The following is a description of a gene set: Human Gene Set: FOXN3_TARGET_GENES from publication Yevshin I, Sharipov R, Kolmykov S, Kondrakhin Y, Kolpakov F (PMID 30445619) species: Homo sapiens Genes containing one or more binding sites for (FOXN3) in their promoter regions (TSS -1000,+100 bp) as identified by GTRD version 20.06 ChIP-seq harmonization., and this is the list of marker genes: NCOA5, SNURF, NDRG2, SCN4A, ZNF22-AS1, ZC3H6, RNA5SP335, DPY19L1, RAB11FIP2, AGBL2 (AGBL carboxypeptidase 2), CD68, SPTAN1, MIR409, NR2F1, MUC2, GGT1, NEK10, CFAP58-DT, SNORD1C, LINC01237, PKD1L2, REC8, PER2, FBF1, SMG1P3, PCMTD2, RPN2, HIRA, TCTE1, TAF4B, MTF2, FAM90A1, ARMC3, ZC3H18, KRT8P51, ACACB, DLL1, RALB, EHHADH, C2orf92, EMC3, KIF23, HEXIM1, ESYT2, SEC23B, RPL35A, TP73-AS3, MCRIP1, OPTN, HSPA12B, ANXA2R, NDRG3, NEDD8, HAAO, JMJD1C, DLGAP4-AS1, AAMP, ROCK2, RSPH1, C4orf17, FAM86GP, TOM1L2, CRIM1, EXOSC6, SIGMAR1, GAD1, MIPEPP3, DNAJC25-GNG10, B3GNT2, OGFR, TCEA2, HNRNPF, LINC01191, AMBRA1, PGPEP1, HYMAI, TTC7A, FAT1, ARMCX2 (armadillo repeat containing X-linked 2), BBIP1, NEK11, RBKS, TMC8, CAP2, NKAIN2, SYNGAP1-AS1, SRP54, ZNF430, ZNF266, ENSG00000232188, DNAAF5, ZNF84, UBXN2B, RNU6-921P, DTX2, DNAH9, MICA, DNAH3, CEP112, CDH24, MBD3, FBXO36, MCF2L2, ARMC5, MUL1, GALT, CKLF-CMTM1, ZNF653 (NCBI Gene Id 115950), ANKRD42, ZNF460, MYLK-AS1, CXCL6, CCS, ISG15, USP40, CKLF, SNAI3-AS1, SORD, TRDMT1, PRC1, ZNF839, SPAG16, GTF3C1, TAT-AS1, RRBP1, HLA-J, SEC23A-AS1, LYPLA2P2, EFCAB11, UBXN2A, CREBL2, KCNQ1OT1 (KCNQ1 opposite strand/antisense transcript 1), LTA, MECOM, KAT14 (lysine acetyltransferase 14), RAMP2, AMFR, ELMOD2, LINC01388, PRDM5, TENT4B, INTS12, RNF213-AS1, LINC00708, RTF2, DNAJC25, CFLAR, MAT2A, CCDC103, PECAM1, STRBP, PRRT2, C20orf144, MDH1, DPY19L2P3, C12orf76, BHLHE41, CDH11, EFTUD2, NAA20, TYR, CREB1, ANG, LRRC43, TMEM74B, DNAH7, ASPHD1, MIR4466, ANKRD42-DT, EPAS1, KIF3C, BFSP1, KIF23-AS1, SLC35F3, ZNHIT2, FAM234A (NCBI Gene Id 83986), ATRAID, LINC01229, NELFA, TTC12-DT, VAPA, TCP11, MFSD9, FOSB, FBXO44, MATCAP1, H3P37, MUC3A, ZFHX2-AS1, SAMD10, PHF1, FKBPL, ZDHHC1, TRAV4, ETV7, MOCS3, SHOX2, TP53TG3GP, ITGB4 (NCBI Gene Id 3691), CNTD1 (NCBI Gene Id 124817), GEMIN2, TM7SF2, TMEM14B, MROH2A, PCTP, CACNB4, CEP250, SIN3A, MID1IP1, ADA, COX11, AKAP1-DT, KCTD2, ZNF324, GMDS-DT, GJC1, MVD, MHENCR, BTBD3, RUFY4, XRCC5, WDR59, FTCDNL1, CEACAMP2, SIRT3, TTLL6, KLHL18, PANK2-AS1, MLF1, PFN1, USP6NL, UBN2, KCNMB3, CHMP3, ALPI, TMEM39B, STK32C, HSPA4L, CLK3, ATF7IP2, DNAAF4-CCPG1, TADA2B, ESRP2, WFDC3, WBP2, ATP7B, MIR449C, MAP3K14, TRPC6, DGKD (diacylglycerol kinase delta), LINC02564, LINC00639, CEP120, AATK, SUPT5H, CEP41, SNORA50C, MRPL33, EYA2, MT2A, CEP131, C2orf42, ZCCHC17, TTLL5, RAVER2, TPBGL-AS1, GALNS, ATP6V1C2, PIGFP3, BABAM2, CHMP1A, CNEP1R1, SNRPN, B3GALT4, ATG4B, BCAS1, KATNIP, WDR93, MED23, ITGB3BP, IL4R, ALKBH8, RPTOR, PIK3R1, TMEM234, ENTPD6, MIR6081, CCDC121, SNHG10, NEIL1, IQCE, VAX2, SEMA4F, PRKD1, EXD3, PET117, SLC43A2, PEPD, CDCA8, ADGRA1-AS1, GSTA4, RSPH1-DT, LAMC1, PHLDB1, PEX12, TSGA10, NMUR1, USP36, MFF-DT, THAP4, ACOXL, PARAIL, MIR6784, P3H4, LINC00205, RCAN2, SIDT2, RPL23AP7, TRAPPC6A, ACVR2A, PTPN18, RIPK2, MRPL40, TAP2, SPPL2A, DNAL1, EIF6, PIGG, AHSA2P, LINC00426, CASC2, ARHGEF1, ZNF444P1, ARL4A, MRC2, RFC5, TMEM219, CKAP2L, MIR219A1, MPHOSPH10, PIERCE1, SDHAF4, MT-TP, ENSG00000267053, MIR933, GLRX5, FAM174C, PDE6G, BCL6B, KCNIP4, PDCD6-DT, EFCAB12, FBXO15, MON2, EZH1, TGIF2-RAB5IF, RNASE11, CAPS2, RUBCNL, OBSL1, B3GNT7, PKP2, CNOT8, WDR45B, SGK1, PYGB, WDR4P2, PTGES3L, CDH13-AS2, ITGB1BP1, CCDC148, LRP5, TTLL9, HOXD9, ANKEF1, USP24, PARD3B, ANKRD36, BLTP3B-DT, USP2-AS1, TRIB2, RANBP2, C20orf96, CFAP58, OTUD7A (NCBI Gene Id 161725), EIF3I, ITGA3, ACTRT3, LZTS3, C6orf136, ENSG00000277020, SNRPB2, DNAAF4, CYB561, CFAP144, IQCG, SLC4A7, PRADC1, ADGRG1 (NCBI Gene Id 9624), ALS2, TRPT1, PGM1, ZCRB1, EARS2, WARS1, SNRNP40, PPP1R9B, RCOR3, SLC8A1, DNAAF11, RBM39, CNGA4, AIRIM, PIGU, U2SURP, SDC1, BAD (BCL2 associated agonist of cell death), ZNRF2P2, RBM33-DT, PLCL1, SYNGAP1, ACSF3, TULP2, PCK2, AOPEP, LCAT, ABI2, PDXDC1 (pyridoxal dependent decarboxylase domain containing 1), ATP5ME, CHPF, RPL23, GOLM2, TEKT3, PAK1, ZGPAT, USP39, POLG2, C11orf97, PPM1G, FOXJ1, TUBD1, GSAP, TCTN1, TRIM65, NFATC4, NUDT22 (nudix hydrolase 22), ALG11, DCDC2C, PFN1P6, C2CD4A, CDT1, HEXD, RAB37, TOR2A, RRAGC-DT, COL18A1-AS1, SPATA4, FAM230C (family with sequence similarity 230 member C), PKDCC, EXOC3L4, LRFN5, SLC4A2, MIR3188, MIR4470, MIR221, RC3H2, PTMA, LIME1, RIPOR3, CFAP221, ODF2, GCC2-AS1, RGS17, PIK3R5, RBMS1, PDCD6, PAQR9-AS1, ATIC, LRRC45, SIRT5, SAMD12, PIEZO1, AHI1-DT, FLYWCH2, ADCY4, GNB1L, FGF11, AGXT, MCEE, PRKRA (NCBI Gene Id 94716), MBTPS1, BOK, NPAS2, WDR25, CTCF-DT, LINC02980 (NCBI Gene Id 124906555), LRP6 (NCBI Gene Id 4040), SNX29, AGBL5, MIR4730, ARL4C, PKD1P4, GRINA, WDPCP, CARMIL2, MFSD4B, TP53RK-DT, MPHOSPH6, ZNF217, ALG1, CARMIL3, EPN3, SPATA2, GGCX, ENSG00000282936, RAB40C, CACNG6, POLR1H, DSTN, DTNB, ANAPC1, ASXL1, CCDC30, COX6A1P2, TTLL4, NDRG4, UCHL1-DT, TTYH2, BAIAP2, MUC6, SLC16A14, RGS22, AIG1, MSL1, OGFOD3, SPRED2, TFB2MP1, PTRH1 (NCBI Gene Id 138428), GMPR2, SCLY, PPP1R7, EFCAB10, DENND6B, FAM187A, TBPL1 (TATA-box binding protein like 1), BBS5, RAB40B, MZF1, SLC1A4, RPS3AP1, CYBRD1, DNTTIP1, HSPB6, PRPSAP1, SSB, PPP4R4, HMGN3, GSTZ1, ENSG00000259881, CCM2L (CCM2 like scaffold protein), CFAP96, ZNF316, IL20RA, TNRC6A, FBRS, TRIP12, SMG1P1, ADGB-DT, RNF111, ZNF529, STXBP6, PHOSPHO2, ARHGDIA, FASN (fatty acid synthase), TIMP2, EIF1, SAMD14, YPEL5, CFAP43, LINC01934, SYCP2, LNPK, TMEM198, STK25, AHI1, RBM15-AS1, RSPH14 (radial spoke head 14 homolog), RUNDC1, STMP1, ZNF367, KPNA1, PPP1R2P10, AANAT, CLTB, SEMA4C, KIAA1671, TNRC6C, PHF3, LIMS2, HSBP1, CACNA1G, EFHC1, ARFGEF2 (NCBI Gene Id 10564), MGC16275, LINC02978, CCNB2, NRSN2-AS1, CFAP263, RBM12B-DT, ATP6V1G1P5, FOXF2, ARHGAP5-AS1, NDUFAF6, ACTR3, GLI2, MIR541, KCNAB2, MIR339, FAM161A, RBFOX3, THNSL2, EPCIP-AS1, PTPRA, FERMT1, ADI1, LYRM4, PCDHA5, MARCKSL1P2, IL34, WDCP, OSCP1, UQCC6, GPATCH2, RHOQP3, TMEM101, LASP1, PEX5, POLD3, SEC23A, PRSS12, NAPB, IFI35, KIF6, TGIF2, RIIAD1, MKS1, TOMM7, CCNO, PAXBP1, CENPX (NCBI Gene Id 6800), SNORA71D, CDR2-DT, PPM1B-DT (PPM1B divergent transcript), RAET1L, KLHL23, STK11IP, CCDC191, TMEM131, DM1-AS, CCDC39-AS1, MIPEP, PSMD10, PDE4DIPP8, SCO1, RAMP1 (NCBI Gene Id 10267), ENSG00000283291 (NCBI Gene Id 110467522, 5.8S ribosomal RNA), TBC1D16, RTKN (NCBI Gene Id 6242), TMEM225B, PJVK, KATNAL1, SNORC, TCFL5, CHKA-DT, IGKV1OR2-3, BRD2, GZF1, CDSN, BCL2L1, HGS, ZBTB9, TPTE, ATXN2L, C14orf119, DCBLD1, LRRC46, HSP90AB1, ZNF497, WBP1, MBTPS1-DT, DYNC1I2, ANTKMT, MORN2, PXDN, MTX1, CPAMD8, CBFA2T3, COL9A3, TFAP2C, CEP97, NAV3, METTL9, ATP5PDP1 (ATP synthase peripheral stalk subunit d pseudogene 1), RN7SKP152, MIR208B (microRNA 208b), VEGFB, RTL10, FNBP1, WDR90, CABIN1, NRL (NCBI Gene Id 4901), SLC2A10, HSD17B1, NDE1, ENSG00000260005, ARIH2, CDR2, NTSR1, PRUNE2, KDM8, MTCL2, NELFCD, LMCD1, FLII, FBLN7, COA3, SEPTIN10, PRKCD, MLF1-DT, GNAO1-DT, FAM217B, STX8, NRSN2, HELZ (NCBI Gene Id 9931), RHBDF2, IQANK1, KDM3A (NCBI Gene Id 55818), HDAC4, UAP1, RNF157-AS1, KIF17, KIFC3, FHIP1B, WTAP, AP1S3, ADISSP, CARS2, PARD6A, RABGGTA, RPS20P5, CEP43, SCARNA13, SPEG, TOP2B, LGALS3BP, ARID1B, LRGUK, PLEKHG4, NPAS3, SFT2D1 (SFT2 domain containing 1), H2AC15, USP34, POLE4, DCTN1, ANAPC7, USP34-DT, SPATA20, CAMTA2, CCT7, ZBBX, RABL2B, HCG25, PANK2, SMARCD2, SCUBE3, FAM182B, ARFGAP1, SKIDA1, RALGAPA1, ZNF747-DT, TMEM232, P3H2, GGCTP1, PANX1, HID1, TK2, ZNF382, MUCL3, ADPRM, SYS1-DBNDD2, MROH8, ZNF23 (NCBI Gene Id 91855), SEPSECS-AS1, GPN1, TBC1D8, FAM110A, CBX1, FAM230E, PARD6B, LINC01153 (long intergenic non-protein coding RNA 1153), MATN4, LPIN3, SH2D6, RPL13, NUBPL, MPC1, PAGR1, GRHL1, SNORD68, KIAA1191P2, ZNF414, EPB41L1, B9D1, BTRC (beta-transducin repeat containing E3 ubiquitin protein ligase), CCND3, LINC02934, JSRP1, SLC2A4RG, DNPEP, BAHCC1, TRAPPC2L, MIR6810, TTC16, CIRBP, WDR27, TXNDC17, PHETA2, EEF1A2, CACNB1, NT5DC1, C16orf46, JUP, TASP1, MIR3939, AAAS, C2orf72, DVL1, CCNO-DT, DYRK3-AS1, CELA3B, PSMF1 (proteasome inhibitor subunit 1), PPM1E, TBC1D8-AS1, SMPDL3A, HSDL1, CFAP44, CUL7, DPY19L2, USP30, PPDPF, FGL1, ZFAND2B, SEZ6L2, DDX11L17, ENSG00000221638, PRKCA (protein kinase C alpha), SNORD104, SPACA9, BOLA3-DT, CRYBB2, RNF139, IFT140, MIR193BHG, ANP32A, CHID1, KLF4, ARMC10, ZNF721, SALL2, RBM23, MYBL2, CEP126, MAP3K13, JPT1, POLR1HASP, MIR6819, PDE6D, MIR1302-3, HSPA1B, OAZ1, SPHK1 (sphingosine kinase 1), SPECC1, PPP1R42, SPATS2L, RN7SL652P, ZFYVE28, C2orf15, CDC20B, ZNF396, TTC8, RRAS2, TLK1, KIF9, DCAF13, UAP1-DT, SNED1-AS1, CLBA1, PNMT, CFAP99, MIR149, PEX11A, FRMD3-AS1, KCNJ1, DYRK3 (NCBI Gene Id 8444), SLC40A1, PDGFB, SANBR, PITPNM3, HACD2, LITAF, SLC11A1, IFT52, DIPK1A, ADGB, STAT5B (signal transducer and activator of transcription 5B), PAK5, ZSWIM3, CRNKL1, KIAA0753, UBXN11, EAPP, FHAD1, ACTR2, ERG28, SLC9A5, NFATC3, ZNF487, UBE2C, C1QTNF1-AS1, RANBP10, FBXW9, FBXO2, RTEL1-TNFRSF6B, SHQ1, C16orf95-DT, ZDHHC7, CCDC157, CD22, LNMICC, MT1JP, POMT2, PPP1R16A (protein phosphatase 1 regulatory subunit 16A), NOL7, FLVCR2, MRPL18, ATOH8, LINC00114, C1DP2, IL5, PLEKHM3, KCNB1, IQSEC3P3, GPD2, SUPT20H, KRT23, DYNLL2, ORC2, ROPN1L-AS1, ZNF439, USP2, SPAST, SLF1 (NCBI Gene Id 84250), HMMR, THBS3, FNDC11, SARDH, DNAJA2-DT, ZNF503-AS2, CRIM1-DT, GPR137 (NCBI Gene Id 56834), MIR3132, SRRM2, CFAP126, MITD1, NUP62CL, TLCD3B, PAQR9, GON7, SLC7A6OS, PPP3R1, PDHX, PKIG, CEACAM1, GOSR2-DT, FKBP10, ACD (NCBI Gene Id 82538), YWHAE, CST8, ATP6V0D1-DT, TBXT, RNASEL, GNAO1, HCG18, MIR4664, SPAG16-DT, DNAJC16, RNA5SP473, SPG7, MIR3678, NECAB3, TMBIM6, NRAV, ID1, FOLH1, TMBIM1, SLC5A6, BATF3, PRKAR1A, DIDO1, QTRT2, TARID, PTPN4, SNORA21, ENSG00000260277, SLC17A9, PRSS56, MIR1-1HG, CDC37, DLX4, PITRM1, RNF175, ACOX3, TP53INP2, TRMT12, MFF, FOXA2, TTF1, TTC4, VPS25, IFT56, GFOD1, PRMT5-DT, RSPH9, RAMP2-AS1, AQR, FHL2, ASTE1, MFSD2B (MFSD2 lysolipid transporter B, sphingolipid), FAM177A1, CFAP53, PYCARD, LRP10, FADS6, NFU1, AFG1L, ORC6, MIR4425, PTP4A1, LBX1 (ladybird homeobox 1), DIS3L2, RNU6-7 (NCBI Gene Id 101954275), SRP14P3, RTN4IP1, ZFP64, SPEF1, EIPR1, GPRC5C, LINC02521, FHOD1, TDP1, KCNQ2, TCF21, DPP7, UTRN, ZNF19, PLLP, ARHGEF40, PRMT5, NCR1, DOCK6, ARMC2, CXADR (NCBI Gene Id 95792), PSMB5, CFAP61, TTLL1, MAFTRR, HLA-DMA, MYH9, DHX32, TRIM15, SLC7A6 (NCBI Gene Id 9057), TGM1, RNU6-1059P, DPP8, SUFU, JAGN1, NEURL3, ENTPD7, RAB5C, GRB2, SRPRB, PRKD3, ITSN2, QRSL1, LINC00658, WNT3, RPL23AP82, NFS1, NRP1, FAAP100, ACE, TMEM107, ZMYM3, CRMA, SLC4A11, DCLK2, UQCC1, PUM2, EMC9, RASIP1, DRC3 (dynein regulatory complex subunit 3), PACRGL, VPS16, PKP4 (plakophilin 4), SYNPO2, REM1, EVA1C, DICER1-AS1, ARB2A, TMC6, SIM2, BMP7, INO80E, COL6A1, SF3A1, MGAT4A, PSAP, LAMA5, ENPP3, STT3B, MYOSLID-AS1, SPTBN1, ATG16L1, NRP2, SCRIB, ATG9A, LINC01964, NOTUM, FANK1, CHST10, SPOPL-DT, TRBV7-3, HM13, MRPL30, PPHLN1, DDX54, FZD5, RNASE4, ING1 (NCBI Gene Id 3621, inhibitor of growth family member 1), COQ4, PLCD3, GPR85, PRSS36, SPECC1-DT, RNA5SP248, MEIG1, ENSG00000273523, MAPK14, NT5C, P4HB, GLT8D1, AKAP1, ANKRD40, SPAG4, FOSL2, PCBP1-AS1, MAST4-AS1, PROM2, MAP4K4, LRRC37A5P, XRN2, HLF, CRYM, MYO15B, HOXB6, ABCD3, NLN, ORAI2, TAF4, ZPBP2 (NCBI Gene Id 124626), KRTAP9-6, ITPRIPL2, ENO3, SP110, MFSD4B-DT, ACTR6, MRGBP, CYP26B1, ECEL1P2, TIMM21, CIMAP3, OR2B8P, ENPP4, PLEKHH2, DCDC2, EXOC7, STXBP4, WASHC4, WASHC3, AUTS2, AGPAT1, INO80B, SEPTIN9, FAM151B, ADNP, CHD2, NUBPL-DT (NUBPL divergent transcript), CDK5, KANSL1L, NUDCD2, COG7, RNU4-61P, CACNA1G-AS1, FAT3, MAN2C1, SLC7A8 (NCBI Gene Id 23428), SPESP1, ATXN7L1, ZNF544, ALMS1, DUS1L, MTLN, MYO1B, CDC25B (cell division cycle 25B), MRPS2, FAM151B-DT, SEH1L, GLS, TMX4-AS1, IPO4, TLE3, KIAA0825, SPEF2, MAST4 (microtubule associated serine/threonine kinase family member 4), CASP9, SPATA17, FBXL13, EEF1E1, DNAH10, FRZB, ABHD12, COPS7B, TRMT11, GSPT1, POTEH, CBFA2T2, GSN, PSME1, RABL2A, TMEM67, HES4, WHAMMP2, FUCA2, CUL3, TBC1D10B, BRCA1, CSNK2A1, PPP1R27, PTPRN, SEPSECS, SPATA33, PARP10, HPN, DLGAP4, ADAM23, XPO1 (NCBI Gene Id 7514), MIR3972, MPHOSPH6-DT, CASC3, FOXN3, DNAJA2, EFL1, THOP1, POLR3F, DZANK1, DYNC2I1, H4C1, CCDC57, CFAP206, TRAV28 (T cell receptor alpha variable 28 (pseudogene)), KCNS1, PSMC3IP, IFT74-AS1, CARHSP1, SIPA1L3, RAD50, MGME1, MRPS27, SDHC, IFT88, AGBL5-AS1, LLGL2, FAM174A-DT (NCBI Gene Id 121232371), DDX19B, ENDOV, FAM83C-AS1, ZNF862, SNX3, NUDT2, LINC00511, ACTR3C, UBR7, ARHGAP5, COX4I2, PHKA2, TMEM40, WHRN, DCP1B, ANKRD13D, PLB1, CNOT6, CCDC102A (NCBI Gene Id 92922), DYNLL1, C2orf68, ALG1L10P, ADCY3, SMIM10L2B-AS1, TRIM47, IQCK, MAIP1, NUP153, TTC12, TRUB2, PREX1, LINC01220, TCP1, BLOC1S3, CFAP65, KNOP1, SND1, LIMD2, DNPEP-AS1, RCAN2-DT, E2F4, LINC02313, CPNE1, SGCA, PASK, INTU, IL18R1, MOK, LRRFIP1, ATP13A2, TMEM177, DDX3X, PPP1R16B, LNPEP, HENMT1, SIX5, R3HDM4, HECTD1, GMNN, FBXO41, CCDC40, SOX9-AS1, IFT74, SPRED1, SPMIP8, HNF4G, CFAP54, PBX2P1, ZC3H12D, RNA5SP528, FLT3, PTPN12, DYNC2H1, MRPL10, CXXC1, CHRAC1, TRAPPC12, LIPT1, PLAGL1, SLC66A3, ZNF490, ERCC1, SPCS1, EIF2B4, ROPN1L, SMPD1, HOXD8, C6orf120, DAB1, THBS4, CHGB, MARCHF10, PTPRH, RBM12B, MIR7854, NFE2L1, GTF2E2, REXO1, METTL5, HIRIP3, HAPSTR1, ATP6V0A4, EGLN3, PGM5P2, YTHDF1, LINC02572, SHOC2, HNRNPUL1, POLR2A, GSTP1 (glutathione S-transferase pi 1), JUND, SNHG11, LRBA, NOP56, NEK4, SEC31B, AGRP, TSNAXIP1, PCIF1, ERFE, SNHG16, UBE2O, C16orf46-DT, PRKD3-DT, P3H2-AS1, APIP, PPP1R12A, CFAP52 (NCBI Gene Id 93665), FAM83H, DYNLRB1, MLLT3, SNRPF-DT, HERPUD1, GPR35, RNA5SP452 (NCBI Gene Id 100873697), NPHP1, MYADM, GPRC5B, MARCHF10-DT (NCBI Gene Id 101927877), ZNF750, CFAP184, RING1, PGS1, TMEM14B-DT, CFAP69, C1orf159, SAXO2, NUP85, DNAAF1, SOCS1, SIK3, RPP38, TDRD3, ENSG00000237773, LINC01833, PRR29, DNAAF6, CIMIP6, RBM24, DYNLL2-DT, FAM174A, ARPC1A, PRCD, SNHG25 (small nucleolar RNA host gene 25), HS3ST1, RAD23A, LMLN, NRBP1 (NCBI Gene Id 29959), SRMP1, GGA2, ARHGAP40, TRAF3IP1, ADAM17, JAG2, MLLT6, ADAD2, GDF5, QRICH2, LURAP1L, U2AF2, LINC02970, SNRPF, OXGR1, SMYD5, MYCBP, PDE4A, TOP1, DPM1, MIDN (NCBI Gene Id 94034), ROMO1, RNPEPL1, PRORSD1P, MNS1, TYW5 (NCBI Gene Id 129450), LRRC27, FAM222A, EIF2AK3-DT, CCDC91, KANSL1-AS1, APOB, IL1F10, TTLL10, ATP9A, NAGPA, FAM120B, EBF4, PTGES3L-AARSD1, ZNF460-AS1 (NCBI Gene Id 105372476), SRMS, MDM1, SLC9A3R1-AS1, DHX57, CCND3P1, HDAC4-AS1, PYDC1, DHRS4-AS1, HPS1, SOX5, HELZ2, FARS2, SOWAHC, KANSL1, TRIM39, LINC01087, MLLT10, CFAP210, LTBP3, LNC-LBCS, FOXG1, POGK, RNU1-54P, SOX12, MIR4690, TOX3, CPNE5, ATP6V0C